Given this list of marker genes GFM2, NUP50, SELENOP, CLCN5, FAM9C, GDAP2, SLC4A8, PDE10A, SLC25A53, SIX3, ZSCAN23, SPRY3, HTR1A, ZHX1, KIAA0232, TREM1, SOX12, EPC1, NTRK2 (neurotrophic receptor tyrosine kinase 2), KCNQ3, INO80D, AGPAT3, ONECUT2, WDR26, SFTA3, ATF2, ETS1, EEA1, KCNS1, PSMD11, LRP6, IKZF4 (IKAROS family zinc finger 4), MBNL3, TBC1D23, CDK19, TYRP1, ELOC, CIPC, KCNE1 (potassium voltage-gated channel subfamily E regulatory subunit 1), ING2, SLC25A21, EPHA5, HELZ, NEUROD1, PIEZO2, ISLR, THBS1, SOCS4 (NCBI Gene Id 122809), MMD, PPP1R3B, SH3TC2, KCNMA1 (potassium calcium-activated channel subfamily M alpha 1), SSH1, VAT1L, RCSD1, ICMT, TNRC6B, SLC16A9, LRBA, HOOK3, SEMA3C, TBR1, REEP3, SLC35E3, SLC66A3, CCDC50, TIMM23, SLC35D1, BRPF3, ARL15, PARP11, RLIG1, DOCK1, DMBX1, LZIC, KCNB1, BLCAP, SPDYE3, ARL8B, SLC13A1, WFDC8 (WAP four-disulfide core domain 8), CDR2L, MAP3K9, ITK, SYNGAP1, FZD4, RAD54L2, PBX1 (PBX homeobox 1), VAX1, FBXW2, PIGR, AZI2, HINT1, NDEL1, CARMIL1, RPH3A, SLC25A31, TRIB2, SPDYE5, MMP1, ERC1, UBE3C, PCDHB5, CCL3L3, LINGO1 (NCBI Gene Id 84894), PRKDC, U2SURP, GABRB3, MECP2, COPA, EFNA4, SLK, DIXDC1 (DIX domain containing 1), RIGI, IRF6, ARHGAP42 (Rho GTPase activating protein 42), NISCH, FAM107B, MITD1, ZNF706, RSBN1, DNAJC16, PSMC2, RBM4B, ALB, TRAF3, CPNE8, VWC2, RCOR3, USB1, RAB3IP, OBSL1, SPDYE6, JPH4, ANXA10, POU2F2, CNTF, PPP4R2, MAOB, PICALM (phosphatidylinositol binding clathrin assembly protein), SLC9A7, SRGAP2B, CCSAP, SOS1, CNOT6, ZDHHC2, ZRANB3, PTPRQ, CUL3, NOXRED1, SLC6A15, PCDH17, EHMT1, KCNIP2, LHX9 (NCBI Gene Id 56956), TMEM267, AGMO, G2E3, ZBTB20, UGGT1, UBE2QL1, BCOR (BCL6 corepressor), MARK1, TRMT10C, SPDYE1, R3HDM2, ELF1 (E74 like ETS transcription factor 1), GUCY1A2, TMEM116, FUT9, HTR2A, QSOX2, SLC22A23, NSRP1, SRGAP2C, TIMP3, NOTCH2, LMTK2, SLITRK5, ARHGEF38, NQO1, NME6, PITPNB, CLMP, KAAG1, STON2, BACH2, C9, VPS50, RFC3, RUFY3, TLR3, PABIR3, NTS, ATP11B, AFF4, FRZB, CNGB3, MOB1A, here is a description of the gene set: Genes predicted to be targets of miRBase v22 microRNA hsa-miR-5197-3p in miRDB v6.0 with MirTarget v4 prediction scores > 80 (high confidence targets). species: Homo sapiens Human Gene Set: MIR5197_3P from publication Chen Y, Wang X (PMID 31504780)